The following is a description of a gene set: Catalysis of the reaction: 3',5'-cyclic AMP + H2O = AMP + H+. studied in species Homo sapiens Human Gene Set: GOMF_3_5_CYCLIC_AMP_PHOSPHODIESTERASE_ACTIVITY, and this is the list of marker genes: PDE9A (NCBI Gene Id 5152), PDE6B, PDE4A, PDE2A, ENPP1, PDE6A, PDE6C, PDE11A, PDE1C, PDE4B, PDE7B, PDE3B, PDE8A, PDE1B, PDE7A, PDE4C, PDE10A, PDE4D, PDE8B, PDE5A (NCBI Gene Id 8654), PDE3A, PDE1A